Given this list of marker genes SOX11, ARID1A, SMARCD1, SOX4, KDM6A, DPF2, SMARCE1, RNU4ATAC, ARID2, KMT2D, PYCR2, LMNB1, SMARCB1, ZFX, SMARCA4, VPS13B, ARID1B, SMARCC2, here is a description of the gene set: Human Gene Set: HP_PROMINENT_EYELASHES species: Homo sapiens Eyelashes that draw the attention of the viewer due to increased density and/or length and/or curl without meeting the criteria of trichomegaly. Prominent eyelashes